The following is a description of a gene set: studied in species Mus musculus Genes predicted to be targets of miRBase v22 microRNA mmu_miR_3083b_3p in miRDB v6.0 with MirTarget v4 prediction scores > 80 (high confidence targets). from publication Chen Y, Wang X (PMID 31504780) Mouse Gene Set: MIR_3083B_3P, and this is the list of marker genes: Rab8a (NCBI Gene Id 17274), Dr1, Smg1, Cr2, Gm11545, Dlx5, Slc8a1, Eef2, Ect2, Cacul1, Fuca2, Ahctf1, Lce1d, Hmgcr, Mllt6, Slc25a31, Hfm1, Cmtm4, D630023F18Rik, Pkig, Brd8, Tcf12, Mrpl28, Zfp322a, Kpna4, BC005537, Zfp827, Sgip1, Mip, Taok2, Ifi27l2b, Coro1c, H2bw2, Trim39, Naf1, Ppara, Rpl7l1, Fgg, Prrt4, Shfl, Zbtb5, Isy1, Naa40, Mcm6, Tmed10, Sstr1 (NCBI Gene Id 20605), Atp13a4, Zfp850, Nup160, Unc5c, Prex1, Zfyve26 (NCBI Gene Id 77517), Zfp592, Plekho2, Ahcyl1 (S-adenosylhomocysteine hydrolase-like 1), Elavl4, Dsg1c, Sgpl1, Hs3st3a1, Mtmr7, Ssbp1, Grpr, Ctnnd2, Serbp1, Vezf1, Tpp2, Ttc9c, Lyn, Cdc23, Mcph1, Dcun1d3, Tanc2, Eif2s1, Mzt1, Nccrp1 (non-specific cytotoxic cell receptor protein 1 homolog (zebrafish)), Hspd1, Carf, Chd9, Slc24a3, Slc16a13, Hsf2, Myl12a, Chmp7, Trak2, Ankrd45 (ankyrin repeat domain 45), Rnf169, Etaa1, Gm527, Ythdf2, Tiparp, Dixdc1, Chst14, Gm5431, Tm2d3, Pan3, Pak5, Arid4a (AT-rich interaction domain 4A), Nufip2, Txnip, Spred1, Stxbp6, Fancl, Dcdc2a, Slco5a1, Mga, Tubgcp4 (NCBI Gene Id 74395), Scgb1a1, Ercc6l2, Cemip, Zcchc13, Asph, Mat2a, Hoxc4, Snap23, Pip5k1b, Ubxn2b, Crybg3, Arhgef12, Ubap1, Gemin8, Arl8b, Mcf2l, Hycc2, Cmc1, Lilra5, Camk1d, Maml2, Lmo4, Necap2, A430005L14Rik, Elovl2, Kdm1b, Pgs1, Fibin, Map3k7cl, Slco2b1, Dus1l, Eda2r, Strada, Prkar2b, Slc13a5, Ilf3, Arb2a, Zc3h13, Wt1, Nhlh2, Med14, Cand1, Gtf2a1, Sumo1, Muc20, Pld1, Nlrp10, Irag1, Rc3h1, Lurap1l, Cplx2, Donson, Sertad2, Nsf, B3gat1, Gria3, Fzd4, Set (SET nuclear oncogene), Habp2, Mxd1, Plac9, Neurod4, Slc24a2, Cmah, Eqtn, Cmtm5, Papolg, Sgms2, Nfat5, Mef2c, C1qtnf3, Pgrmc2, Zfp39, Hnrnpll, Cdhr1, Rem2, Gm12185, Npas3, Lmbrd2, Ak3, Fitm2, Rb1, Wdr95, Sfxn1, Tigd4, Rassf3, Plekhf2, 1110059G10Rik, Atg13, Hif1a